Given this list of marker genes Ccnb1, Lbr, Lmnb1, Emd, Lmna, Kpnb1, Vrk2, Ppp2r2a, Vrk1, Cdk1, Ankle2, here is a description of the gene set: This event has been computationally inferred from an event that has been demonstrated in another species.<p>The inference is based on the homology mapping from PANTHER. Briefly, reactions for which all involved PhysicalEntities (in input, output and catalyst) have a mapped orthologue/paralogue (for complexes at least 75% of components must have a mapping) are inferred to the other species. electronically inferred by orthology from the curated human pathway studied in species Mus musculus part of: Nuclear Envelope (NE) Reassembly Reactome Pathway: Initiation of Nuclear Envelope (NE) Reformation